The following is a description of a gene set: part of: Transmission across Chemical Synapses studied in species Homo sapiens Reactome Pathway: Neurotransmitter clearance Neurotransmitter released in the synaptic cleft binds to specific receptors on the post-synaptic cell and the excess of the neurotransmitter is cleared to prevent over activation of the post-synaptic cell. The neurotransmitter is cleared by either re-uptake by the pre-synaptic neuron, diffusion in the perisynaptic area, uptake by astrocytes surrounding the synaptic cleft or enzymatic degradation of the neurotransmitter., and this is the list of marker genes: ACHE, SLC22A2, SLC22A1, ALDH2, BCHE, COMT, MAOA, SLC6A3, TOMT, SLC6A4